The following is a description of a gene set: Mouse Gene Set: GOMF_OXIDOREDUCTASE_ACTIVITY_ACTING_ON_A_SULFUR_GROUP_OF_DONORS Catalysis of an oxidation-reduction (redox) reaction in which a sulfur-containing group acts as a hydrogen or electron donor and reduces a hydrogen or electron acceptor. species: Mus musculus, and this is the list of marker genes: Clic3, Pdia5, Txn1, Ifi30 (NCBI Gene Id 65972), Glrx2, Txn2, Tmx1, Coa7, Pdia2, Pdia4, Txnl1, Chchd4, Tmx3, AU015836, Pcyox1, Txndc17, Txnrd1, Selenot, Glrx (NCBI Gene Id 97899), Pcyox1l, Txndc5, Ero1a, Nxn, Ero1b, Sesn2, Gsto1, Msrb2, Sco2, Msrb1, Tmx4, Selenbp2, Suox, P4hb (prolyl 4-hydroxylase, beta polypeptide), Txnrd3, Dnajc10, Coil, Sumf1, Tmx2, Txnrd2, Pdia6, Txndc2, Pgk1, Msra, Srxn1, Txndc12, Selenbp1, Qsox2, Msrb3, Pdia3, Gsr, Qsox1, Gfer, Sqor, Gsto2, Dld